Given this list of marker genes PTF1A, LHX1, PDX1, CNOT1, GATA6, HNF1B, here is a description of the gene set: Pancreatic aplasia Aplasia of the pancreas. Human Gene Set: HP_PANCREATIC_APLASIA studied in species Homo sapiens